The following is a description of a gene set: EWS/FLI-1 is a chimeric oncogene generated by chromosomal translocation in Ewing tumors, a family of poorly differentiated pediatric tumors arising predominantly in bone but also in soft tissue. The fusion gene combines sequences encoding a strong transactivating domain from the EWS protein with the DNA binding domain of FLI-1, an ETS transcription factor. A related fusion, TLS/ERG, has been found in myeloid leukemia. To determine EWS/FLI-1 function in vivo, we engineered mice with Cre-inducible expression of EWS/FLI-1 from the ubiquitous Rosa26 locus. When crossed with Mx1-cre mice, Cre-mediated activation of EWS/FLI-1 resulted in the rapid development of myeloid/erythroid leukemia characterized by expansion of primitive mononuclear cells causing hepatomegaly, splenomegaly, severe anemia, and death. The disease could be transplanted serially into naïve recipients. Gene expression profiles of primary and transplanted animals were highly similar, suggesting that activation of EWS/FLI-1 was the primary event leading to disease in this model. The Cre-inducible EWS/FLI-1 mouse provides a novel model system to study the contribution of this oncogene to malignant disease in vivo. Human Gene Set: TORCHIA_TARGETS_OF_EWSR1_FLI1_FUSION_TOP20_DN species: Mus musculus from publication Torchia EC, Boyd K, Rehg JE, Qu C, Baker SJ (PMID 17875932) Top 20 down-regulated genes in leukemic progenitor cells expressing activated fusion of ESWR1 and FLI1 compared to normal hematopoetic progenitors., and this is the list of marker genes: DOCK10, SMO, PHGDH, PRKD3, SOX4, HOXA9 (homeobox A9), GALNT7, GRB10, CNN3, TGM2, PTGR1, CDC42EP3, SLC6A13, CD81, LGALS1, TMSB10, PPBP, ARHGAP15